The following is a description of a gene set: Human Gene Set: HP_INTELLECTUAL_DISABILITY_BORDERLINE Borderline intellectual disability is defined as an intelligence quotient (IQ) in the range of 70-85. studied in species Homo sapiens Intellectual disability, borderline, and this is the list of marker genes: TBC1D24, CLDN11, DHX9, CPLX1 (NCBI Gene Id 10815), SRPK3, AASS, OCA2, SNRPN, GRIN2A, TRAPPC11, IFT172, NUDT2, NDN, CHD8, TONSL, GABRG2, POLD1, YY1AP1, NRAS, SRPX2, POMK, KCNMA1, SCN8A (NCBI Gene Id 6334), TRIO, ENTPD1, MAGEL2, SCN3A, ALOX12B, ALOXE3